The following is a description of a gene set: Neighborhood of DEAF1 deformed epidermal autoregulatory factor 1 (Drosophila) in the GCM expression compendium Neighborhood of DEAF1 Human Gene Set: GCM_DEAF1 studied in species Homo sapiens, and this is the list of marker genes: TMEM184B, USP33, GPR153, DCUN1D4, DDHD2, HERC2, TMEM30A, FAM168B, UBQLN2, RAB14, UBE2K, RAPGEF2, ENSG00000291228, DNAJB14, UBQLN1, FBXO9, MAPK8IP3, FOXJ2, BLTP1, FAM219A, YWHAG, FBXW11, NAPG, DEAF1, G3BP2, GPR107, TRIM44, MOAP1 (modulator of apoptosis 1)